The following is a description of a gene set: Genes predicted to be targets of miRBase v22 microRNA mmu_miR_92a_1_5p in miRDB v6.0 with MirTarget v4 prediction scores > 80 (high confidence targets). from publication Chen Y, Wang X (PMID 31504780) studied in species Mus musculus Mouse Gene Set: MIR_92A_1_5P, and this is the list of marker genes: Gng4, Anks1, Gabrp, Hdlbp, Hrk, Apln, Kcnk10, Bsg, Pkib (protein kinase inhibitor beta, cAMP dependent, testis specific), Fbxw7, Msi2, Sema5a, Slc25a23, Zrsr2, Ivl, Fbxl16, Il1rap, Iqsec3, Nfic, Foxp4 (NCBI Gene Id 74123), Ankfn1, Mrpl41, Elk1, Zfp593 (zinc finger protein 593), Cdh4, Slc11a2, Ciao1, Pink1, Tspan18, Prr29, Rasgef1a (NCBI Gene Id 70727), Slc2a1, Tob1, Magi1, Sord, Arfgef3, Pld1, Serpina6, Ppp2r1a, Arhgap35, Prpf3, Ilf2, Fam13c, Trps1, Ppme1, Ascl1, Zhx3, Crocc2, Ensa, Cd59a, P2rx7, Hspb6, Kcnma1, Dmbx1